Given this list of marker genes YPEL3, SAMD3, TBC1D12, FBXL12, CEP95, CRELD2, PTTG1, IRAG1, CASP1, EPC1 (NCBI Gene Id 80314), DYNLT3, ING1 (inhibitor of growth family member 1), BLCAP (BLCAP apoptosis inducing factor), SH2D1A, PGM2L1, GCH1, DDX60, YAF2, ZDHHC20, FRG2B, GGNBP2, ARMCX5, ANKRD24, TRIP11, AREG, TRAF5, MARCHF7, CLGN, ARMCX3, ADGRG1, ARF4, OFD1, FAM50B, HOOK3, NR3C1, UBE3A, ST8SIA4, TNFSF4, KIF5C, FMO5, CREM, DNAJB9, IGFLR1, PIGP, IFIH1, RGS1, GAB3, ZBTB2 (NCBI Gene Id 57621), DUSP1, KIN, CCL4, DNTTIP2, CLK1, CCNG1 (cyclin G1), CR2, SERPINI1 (serpin family I member 1), FNDC5, JUNB, PPM1B, LCE1B, EIF1, CCDC70, ZEB2, ATF7, PARP8 (NCBI Gene Id 79668), N4BP2L1, SRXN1, SLC7A6OS, PGLYRP3, CBR1, SLC26A2, KLRC2, FAM120B, VPS37A, CHD9 (chromodomain helicase DNA binding protein 9), MX2, PRSS2, AKAP8L, ZRANB1 (zinc finger RANBP2-type containing 1), LATS2, COQ10B, FABP3, RNF2, VGLL1, AKAP9, FIBP, RNF43, PFN2, CCL5, SNAP47, MBLAC2, TMEM9B, CHPT1, PHF21B, LDHB, IL15, LRRC23, FOXC2, CD3G, TTC3, FOXO3, NRARP, APOBEC2, KCNIP3, HERPUD2, MAPKAPK5, CARD6, IRF2BP1, PPP1R12A, CDC42EP3, EOMES, ZUP1 (zinc finger containing ubiquitin peptidase 1), CD55, NKIRAS1, PLSCR1, KIZ, S1PR5, NOL8, KMT5B, DCP1B, EPC2, RSF1, MGST2, PDP1, SPAST, CIR1, TBC1D4, ADRB2, CHD3, BAZ2B, YTHDF1, GLCCI1, ARL4C, LRATD1, RMI1, ULK2, ICA1L, PENK, MPPE1, LENG9, CD7, ARHGEF17, CASP4, POLR2M, GEM, KLF2, WLS, FBXO32, CALCRL (calcitonin receptor like receptor), here is a description of the gene set: species: Homo sapiens Genes up-regulated in T reg: induced versus natural. Human Gene Set: GSE14415_INDUCED_VS_NATURAL_TREG_UP from publication Haribhai D, Lin W, Edwards B, Ziegelbauer J, Salzman NH, Carlson MR, Li SH, Simpson PM, Chatila TA, Williams CB (PMID 19265124) The gene expression profile of peripheral Foxp3+ natural regulatory T cells isolated from Foxp3/EGFP bicistronic mice was compared to that of in vitro-induced regulatory T cells and to CD4+ conventional (Foxp3-) T cells. The role of the regulatory T cell transcription factor Foxp3 in shaping the transcriptosomes of natural and induced regulatory T cells was analyzed using mice expressing a mutant FOXP3-EGFP fusion protein (Foxp3deltaEGFP). We used gene expression microarrays to examine the transcriptional programs of natural and induced regulatory T cells and the function of Foxp3 in organizing the transcriptosomes of the respective cell type